Given this list of marker genes Ifi202b, Irgm1, Il6st, H2-Ab1, H2-Ea, C1qc, Fas, Gbp2b, Ifi204, Psme1, Ms4a4d, Fkbp11, Mt1, Cd5l, Itpk1, Nampt, Hck, Col4a1, Ctla2b, Bcl2a1a, Ifi205, 4833445I07Rik, Ptpn1, Lcp2, Serpina10, Tmsb10, Samhd1, Vcam1, Lyz2, Ifit1, Cd53, Zic3, Eif1a, Procr, Uba7, Psmb10 (NCBI Gene Id 19171), Atp11a, Mpeg1, H2-DMb1, Socs1, Nek9, Xdh, N4bp1, Lilrb4b, Gbp7, Ifi47, 1110038F14Rik, Ifi207, Fkbp5, Ccl7, Rnf19b, Ccl2, Ifi35, Gbp2, AW112010, Pld4, Lbp, Flot1, Tyrobp, Pkm, Icam1, Shisa5, Gbp3, Cyba, Ifi27, Akap9, Marco, Eogt, H2-Aa, Iigp1, Nfkbiz, Stat1, Il18r1, Wars1, Psmb9, Mak16, Irf7, Krt18, Irgm2, H2-T10, Ly86, Ifit3, Serpina3g (serine (or cysteine) peptidase inhibitor, clade A, member 3G), Tap1, Ccl6, Tmsb4x, Ly6a, Slc11a1, Cxcl10, Pld3 (phospholipase D family member 3), Cxcl9, Isg15, Gimap4, Lgals3bp, Tff3, Irf1, Cryaa, Ear2, Ear1, Ly75, Tap2, Msr1, Rps6kc1, Il18bp, Clic1, Tapbp, Fgl2, Snx10, H2-Eb1, Psmb8, Saal1, Orm3, Ptgs1, Usp18, Il1rn, Psme2, Tgtp1, Adgre1, Nfkbia, Cdc42se2, Litaf, C1qb, Cd74, H2-DMa, Ctss, Plac8, Crybg1, Irf8, Cxcl1, Cd14, here is a description of the gene set: Mouse Gene Set: ICHIBA_GRAFT_VERSUS_HOST_DISEASE_D7_UP The liver, skin, and gastrointestinal tract are major target organs of acute graft-versus-host disease (GVHD), the major complication of allogeneic bone marrow transplantation (BMT). In order to gain a better understanding of acute GVHD in the liver, we compared the gene expression profiles of livers after experimental allogeneic and syngeneic BMT using oligonucleotide microarray. At 35 days after allogeneic BMT when hepatic GVHD was histologically evident, genes related to cellular effectors and acute-phase proteins were up-regulated, whereas genes largely related to metabolism and endocrine function were down-regulated. At day 7 after BMT before the development of histologic changes in the liver, interferon gamma (IFN-gamma)-inducible genes, major histocompatibility (MHC) class II molecules, and genes related to leukocyte trafficking had been up-regulated. Immunohistochemistry demonstrated that expression of IFN-gamma protein itself was increased in the spleen but not in hepatic tissue. These results suggest that the increased expression of genes associated with the attraction and activation of donor T cells induced by IFN-gamma early after BMT is important in the initiation of hepatic GVHD in this model and provide new potential molecular targets for early detection and intervention of acute GVHD. studied in species Mus musculus from publication Ichiba T, Teshima T, Kuick R, Misek DE, Liu C, Takada Y, Maeda Y, Reddy P, Williams DL, Hanash SM, Ferrara JL (PMID 12663442) Hepatic graft versus host disease (GVHD), day 7: up-regulated in allogeneic vs syngeneic bone marrow transplant.